Given this list of marker genes TSPEAR, CXADR (NCBI Gene Id 95792), ABCA4, TPMT, SNTG2, NRG3, EFCC1, SLCO5A1-AS1, CALHM6, PEX16, TMEM217, LINC01948, NRP2, TMEM63C, ASGR2, SCAMP5, NFIA-AS2, PPFIBP1, NTS, RPL26L1-AS1, P4HA3, ARL4A, ZNF436-AS1, MFSD4A, FAM120A2P, GCOM1, TBX1, GPRIN1, RAPGEF4, PTX3, CELSR1, EFNA5, KBTBD11, KLHL4, FLT4, GSK3B-DT, LINC02147, PIK3C2G, STAP2, CCL21, CMKLR2, RASSF9, SLC35E4, MYZAP, SHC1, SLC39A14, ANKRD36BP2, NALCN, IL7, GJC2, PCLO, DLK2, CEP19, KCTD17 (NCBI Gene Id 79734), SFTA1P, TFF3, PROX1, LINC00920, KLHL14, SEC14L2, CYTL1, PLIN5, STAB2, MYL12-AS1, GJA1, PARD6G (NCBI Gene Id 84552), KLHL3, GPM6A, KLKB1, LINC02133, C6orf141, HAND2, NHLRC1, UNC5A, here is a description of the gene set: species: Homo sapiens from publication Cao J, O'Day DR, Pliner HA, Kingsley PD, Deng M, Daza RM, Zager MA, Aldinger KA, Blecher-Gonen R, Zhang F, Spielmann M, Palis J, Doherty D, Steemers FJ, Glass IA, Trapnell C, Shendure J (PMID 33184181) Marker genes curated from the annotated cluster as represented in the Descartes Human Gene Expression During Development database. Human Gene Set: DESCARTES_FETAL_MUSCLE_LYMPHATIC_ENDOTHELIAL_CELLS The gene expression program underlying the specification of human cell types is of fundamental interest. The study authors generated human cell atlases of gene expression and chromatin accessibility in fetal tissues. For gene expression, the study authors applied three-level combinatorial indexing to >110 samples representing 15 organs, ultimately profiling ~4 million single cells. The study authors leveraged the literature and other atlases to identify and annotate hundreds of cell types and subtypes, both within and across tissues. Our analyses focused on organ-specific specializations of broadly distributed cell types (such as blood, endothelial, and epithelial), sites of fetal erythropoiesis (which notably included the adrenal gland), and integration with mouse developmental atlases (such as conserved specification of blood cells). These data represent a rich resource for the exploration of in vivo human gene expression in diverse tissues and cell types.